Given this list of marker genes ITGB4, ITGA9, ITGA3, ACTB, FN1 (fibronectin 1), ITGA2, ACTN1 (NCBI Gene Id 87), TLN2, ITGA10, ITGB1, ITGB5, PTK2, ITGB3, TLN1, ILK, ITGA2B, ITGA8, ITGA11, VCL, ITGA5, ITGAV, ITGA7 (integrin subunit alpha 7), ITGA4, ITGA1, ITGB7, PXN, ITGB8, ACTN4, ACTG1, ITGB6, here is a description of the gene set: Pathway Definition from KEGG: FN1 -> (ITGA+ITGB) -> (PTK2+PXN+ILK) -> (TLN+ACTN1/4+VCN) -> (ACTB,ACTG1) species: Homo sapiens ITGA/B-TALIN/VINCULIN signaling pathway. Pathway ID: N01080. Pathway type: Reference. Pathway class: nt06135 Cytoskeletal regulation (viruses and bacteria). Human Gene Set: KEGG_MEDICUS_REFERENCE_ITGA_B_TALIN_VINCULIN_SIGNALING_PATHWAY